Given this list of marker genes Satb2, Tnn, Hdac4, Hoxa2 (NCBI Gene Id 15399), Jund, Msx2, Ache, Runx2, Pthlh, Pth1r, Hdac5, Lrp5, Hey1, Gli2, Limd1, Clec5a, Shh, Smad3, Men1, here is a description of the gene set: Mouse Gene Set: GOBP_OSTEOBLAST_DEVELOPMENT species: Mus musculus The process whose specific outcome is the progression of an osteoblast over time, from its formation to the mature structure. Osteoblast development does not include the steps involved in committing a cranial neural crest cell or an osteoprogenitor cell to an osteoblast fate. An osteoblast is a cell that gives rise to bone.